The following is a description of a gene set: species: Homo sapiens Any process that activates or increases the frequency, rate or extent of apoptotic cell clearance. Human Gene Set: GOBP_POSITIVE_REGULATION_OF_APOPTOTIC_CELL_CLEARANCE, and this is the list of marker genes: ABCA7, C4B, C3, C4A, C2, CD300LF, TREM2, CCL2